The following is a description of a gene set: species: Homo sapiens Human Gene Set: HP_RECURRENT_MALADAPTIVE_BEHAVIOR Recurrent maladaptive behavior A repeating behavior that is either immediately unproductive or has negative long-term consequences. This includes harmful coping mechanisms such as addictive behavior and failure to control impulses and compulsions., and this is the list of marker genes: TAS2R16, KIF14, SETD2, SQSTM1, CLCN2, SLC1A4, SKI, UQCC2, IGF2, FOXG1, PAX4, SLC25A1, SPATA7, BRCA1, DHPS, MEFV, GLYCTK, PDGFRB, DHTKD1, NDST1, DRD2, LEMD3, SLC6A1 (solute carrier family 6 member 1), NR4A2, CDKN1A, NAT8L, EZH2, OCA2 (NCBI Gene Id 4948), CIC, TUBB3, RIC1, UBE2A, SMC5, BANK1, ATR, CTNNB1, ARPC4, BRAF, TMEM240, ZBTB18, IFNG, PSEN2, SYT1, ADH1B, GABBR2, KIAA0319L, TMEM270, ZEB2, SLC25A22, CCND1, SCN3A, HDC, TREM2, FANCL, ZFX, SOX3, CACNB4, KCNH5 (potassium voltage-gated channel subfamily H member 5), SLC9A7, SLC3A1, DALRD3, SMARCA4, CERT1, KMT2A, UBE3A, GABRB2, CSGALNACT1, DDC, ATRX, ASCC3, NOP56, DDX6 (NCBI Gene Id 1656), ZMYND11, PTEN, MPL, PGAP1, OCRL, PNP, GLI3, FZR1, ALMS1, USP8, HIRA, PSMD12, PTPN3, TSC2, LNPK, FGF14, TDO2, TBK1, SMAD4, LINGO1, BAZ1B, KCNQ3, SH2B1 (SH2B adaptor protein 1), FBXW11, BCAP31 (NCBI Gene Id 10134), CEP152, ALKBH8, GRIN2D, GNAQ, PDSS1, CAPRIN1, ATG7, CDH2, GABRA1, RAB39B, GJA5, ATXN10, TRIO (trio Rho guanine nucleotide exchange factor), GNB2, ADCY5, SCAF4, EXTL3, HUWE1, PDGFB (platelet derived growth factor subunit B), MSH6, STAT5B, BCL11A, SIN3A, NAA15, SLC45A1, SLC1A2, CNKSR2, GUCY2D, CILK1, TUBA1A, AP4S1, CYP27A1, NACC1, ZMIZ1, UBE4A (ubiquitination factor E4A), HECW2 (HECT, C2 and WW domain containing E3 ubiquitin protein ligase 2), TAOK1, SMC3, UCHL1, GATA4, CPLX1, GNAI1, DRD4, NPC2, HTRA2, MEF2C, AARS1, IRF2BP2, ATP6V1A, KDM5B, CORO1A, CHD2, GRB10, TACO1 (NCBI Gene Id 51204), RLIM, IQSEC2, PRRT2, ABCD1, ITGAM, GLS, ADCY3, FAS, ASXL3, SLC13A5, VARS1, SNAP25, CBS, NDE1, DPYS, KCNC2, CCNK, TAF4, CLIP2, NPHP1, TTI2, RPS20, ZNF526 (zinc finger protein 526), AVP, TNIK, PCYT1A, AUH, ASPM, DPAGT1, AGO2, HDAC8, ARID1B, SETD5, HTR2A, SPG7, KDM4B (NCBI Gene Id 23030), AP1S2, PAK3, ALDH4A1, PCNT, FLCN, SYNJ1, RAI1, CASP2, CSNK2A1, ACY1, DCTN1, KIF15, NEXMIF, DLG3, SCN8A, EFHC1, HCN1, NSUN6, SLC6A4, AASS, PIEZO2, SLC6A19 (NCBI Gene Id 8062), HTRA1, GPR101, CASR, LZTFL1, NAGS, ZNF365, CHEK2, KMT2E, HEPACAM, TRANK1, DYRK1A, PIGH, KMT2C, HLCS, NIPA2 (NIPA magnesium transporter 2), SOX11, DNAJC12, DNAJC6, ADA2 (adenosine deaminase 2), SLC7A7, IMPDH1, TRAK1, APP (amyloid beta precursor protein), FRMPD4, NARS1, PITRM1, GATAD2B, OFD1, RFX7 (NCBI Gene Id 64864), SHMT2, SLF2, NAA80, TBX2, HLA-DRB1, METTL5 (NCBI Gene Id 29081), KCNN2, ARX, CEP104, FGFR3, MYT1L, KPNA3, TULP1, CHCHD10, NLRP3, IFT140, ASXL1, COG3, SLC52A2, PPP3CA, CDK13, MED13, ABCA2, PRKD1, MICU1, AQP4, ZMYM3, CRB1, HSPG2, CABP4, ANAPC1, GDAP2, BSND, AFF2, UNC93B1, SOX5, KCNA2, FGFRL1, FGFR1, SNRPN, RARA, AP3B2, NPM1, PRKAR1A, ZIC2, GNB1, LEP, GABRA2, CC2D1A, HIVEP2, ITPR3, PDPN, TARDBP, CEP290, FGF13, STT3A, HSD11B2, PYCR2, SIN3B, EMC10, NAPB, GRIA3, UFD1, PTPA, LETM1, DNAJC13, NFASC, FCGR3B, SPEN (NCBI Gene Id 348488), KCNJ5, PHF21A, SYN1, TNFSF4, NSD1, MBD5, DPYD (NCBI Gene Id 1806), CHD3, LARP7, ESS2, LINS1, SLC9A6, PGM2L1 (NCBI Gene Id 283209), MAOA, NLGN4X, PIGY, PODXL, CRELD1, RD3, PDZD8, NSDHL, WDR45, MAPT, SNORD116-1 (NCBI Gene Id 100033413), SLC4A1, PPP2CA, BLK, FANCD2 (FA complementation group D2), PKHD1, SLC5A7, SPTAN1, SZT2, UCP2, AP2M1, RPL10, GTF2IRD1, POGZ, STEEP1, CACNA1D, HECTD4, IGF1, SNCA, DLL1, RHOBTB2, TANC2, POLE, PPP2R1A, PWAR1, IQCB1, CCR1, MC2R, CLTC, BCORL1, FGF12, CTLA4, PTRHD1, STAT3, CR2, EHMT1, TNRC6B, MAPK10, PMS2, POMC, BCOR, PARS2, LIMK1, ASH1L, ELN, RNU7-1, AIP, NFIB, COMT, YME1L1 (NCBI Gene Id 115724), SLC32A1, GNAO1, PMS1, RNU4-2, FLI1, AP1G1, HCRT, HDAC4, NFIA, HSD17B10, FBXL3, MYD88, CACNA1B, SLC4A10, PPP1R12A, ATP13A2, LUZP1, GDF6, MRAP, JARID2, GALT, PIK3CA, KDM3B, CAMTA1, RREB1, H3-3A, CACNA1C, VPS35, ALAD, MAPK8IP3, TUBB4B, ATP10A, PRDM16, ALDH5A1, SOX4, STAG2, CDKN2C, GRIK2, CACNA2D1, TCEAL1, PANK2, GRN, TGFBR2, TLR3, OPHN1, PSMB1, PALLD, DPH2, ZMYM2, STX1B, ECM1, GP1BB, ETS1, ACTL6B, CHMP2B (charged multivesicular body protein 2B), NKX2-1, GALC, PIGQ, GTF2IRD2, CASK, ATM, HGSNAT, CYFIP2, ALG13, KCNJ10, ALPL, WBP11, CDKN1B, CARS1, WDR4 (NCBI Gene Id 55896), LEPR, TRAF3, IL6, ARVCF (NCBI Gene Id 421), GLI2, NDN, COQ5, CD3E, TMEM106B, ABCA12, TSC1, TRIM8, HLA-B, NOVA2, NIPBL, SYT2, NFIX, CSF1R, PGAP3, SGCE, GNS, DGCR8, FOXH1, MC4R, EIF4G1, RUSC2, AIPL1, THOC2, JRK, ABCC8, GNB5, CD247, HNF1B, FOXP1, MED25, CRX, RAD21 (RAD21 cohesin complex component), SH3KBP1, STIL, PTCH1, HAL, PDE2A, PNKP, RPS6KA3, NAGLU, DDB1, GCH1, RAC1, KCNAB2, CHAT, NAA10, INSR, BRD4, SMG8, ADH1C (NCBI Gene Id 126), RABL3, TPH2, C4A, EIF4H, NUMA1, PTCHD1, NEUROG1, GAS1, WASHC4, THRB, ENTPD1, MAP1B, HPSE2, FBXO28, GLDC, EPCAM, KIF5C, KIF11, TMEM231, YWHAG, TLR7, KAT6A, IL1RAPL1, C4B, FMR1, AVPR2, IRF5, NUS1, PRNP, ATP1A3, IRF4, MAB21L1, TNFAIP3, MECP2, UNC80, PWRN1 (NCBI Gene Id 791114), FIP1L1, HOXA2, DCHS1, SPR, DGCR6, SLC25A36, MN1, TICAM1 (NCBI Gene Id 148022), BCR, CACNA1A, EIF2AK1, SLC18A3, WFS1, GABRD (gamma-aminobutyric acid type A receptor subunit delta), GTF2I, PRR12, KARS1, MEIS2, POU4F1, CHD7, DYM, CRIPTO, HNRNPK, SPOP, STAT4, TCF4, PML (PML nuclear body scaffold), WDR26, TSHR, TBL1X, WARS2, NECAP1, MGAT2, ANKRD17, CAMK2B, IFNGR1, CHKA, BBS2, RERE, SYNGAP1, CHRNB2, ZDHHC9, DOCK7, CLCN3, CHAMP1, HNRNPH2, TIAM1, GM2A, GNAS, IKBKG, IFT74 (NCBI Gene Id 80173), CASZ1, SEC24C, ITPR1, CLCNKB, NAA60, NLGN3, TBL1XR1, RDH12, WASF1, TP53, AGO1, NMNAT1, MACF1, CDK19, CTSH, KANSL1, SLC2A3, PRODH, SUCLG1, MKRN3, KLRC4, NFS1, IGHG1, CLDN16, NPAP1, KCTD17, DEPDC5, SASS6, MOG, FGD1, MAN1B1, PDE4D, SATB2, DPH1, MMP23B (matrix metallopeptidase 23B), UBE3C, PLA2G6, DDX3X, IL23R (NCBI Gene Id 94006), IL12B, TKT, HTT, AGPAT2, GNE (glucosamine (UDP-N-acetyl)-2-epimerase/N-acetylmannosamine kinase), IMPDH2, PHIP, PROKR2, CUL4B, SOX2, CISD2, DDX59, SIM1, TLK2, CD3D, FRRS1L, CHD8, CDC42BPB, FTSJ1 (FtsJ RNA 2'-O-methyltransferase 1), PRKAR1B, SRSF2, CDK10, SCN1B, KCNJ11, EBP, SLC41A1, CDKL5, TRAPPC6B, FMO3, UBTF, ODC1, WDR62, RTTN, TNPO2, TRAPPC14, CDKN2A, BAP1, COL13A1, PREPL, IL12A-AS1, PDCD1, SHROOM4, KCNA4, ATP1A1, RUNX1, MSH2, CDKN1C (cyclin dependent kinase inhibitor 1C), OTX2, KMT2B, GCSH, MUTYH, WAC (WW domain containing adaptor with coiled-coil), UBE2L3, TBP, CDKN2B, GRM7, ACBD6, NTRK2, ZBTB20, NDP, CAMK2G, SRCAP, PACS1, CELF2, DRD5, KAT8, WBP4, SARS1, TET3, NR2F1, SRPX2, GLA (galactosidase alpha), DPYSL5, P2RY11, KMT5B, FBXO11 (F-box protein 11), TBX1, SETBP1 (SET binding protein 1), NPHP3, NAXD, OTC, CDC73, ERAP1, UBE4B, PSEN1, GJB2, TTI1, SMARCD1, APC2, PRKN, JAZF1, SLC2A1, PXK (NCBI Gene Id 54899), LCA5, CHD5, PIGL, MCTP2, HEPHL1, STXBP1, ATP7B, UPF3B, DHX30, SHOC2, ADAT3, ARG1, BSCL2, EXT2, SLC12A3, JMJD1C, SHANK3, BBS9, PPP1R21, AP4M1, MED12 (NCBI Gene Id 9968), PIGS, SLC35C1 (solute carrier family 35 member C1), NABP1, NLGN1, DNMT1, DNM1L, SLC7A6OS, PINK1, TRAPPC10, DMPK, EBF3, NAA20, TYROBP, LMNB1, GLUD1, TET2, TRIP12, NALCN, ADGRV1, SLC6A8, KCNJ13, RPE65, CHRNA2, MLH1, KCNT1, JAK2, SATB1, SIK1, NKAP, PCGF2, P4HA2, MED13L (NCBI Gene Id 23389), VCP, LRRK2, BPTF, KNL1, SLC38A3, KCNA1, TBL2, RAP1GDS1, TCF20, AP4B1, CRH, PPM1D, VANGL1, VAMP1, UBAC2, IVD, SLC46A1, CREBBP, FLG, AGRN, PRKCZ, FOXP2, IMPA1, FCGR2B (Fc gamma receptor IIb), DGCR2, ARID1A, IQSEC1, NBEA, AFG2A, ZSWIM6, DENND5A, BICRA, FAT4, DEAF1, SUGCT, DYNC1I2, AFF3, HPRT1, GRIA2, SCN2A, AP4E1 (NCBI Gene Id 23431), NIPA1, TAF1, MMUT, RELN, IL10, PCDH19, PLCH1, TREX1, SORL1, SVBP, LHCGR, TRRAP, USP45, TBC1D23, ABCA7, PUF60, DNASE1, NSD2, ATP6V0A1, H4C5, ADGRL1, DNAJC19 (NCBI Gene Id 131118), NPHP4, VPS16, SLITRK1, FKBP6, CBL, GRIA1, EIF2S3, TNIP1, MMADHC, YY1, SCN1A, LGI1, SMARCE1, SUPT16H, TSHB, SLC19A2, SHQ1, ZNF699, APOE, RBL2, NONO, GRIN2A, USP7, CHRNA4, AHDC1, PLAG1, PARK7, COASY, PUS7, EEF1A2, NTNG1, NRCAM, NF1, CYP11B1, TMCO1, CDH11, SCARB2, NBN, FUS, BRF1, ASL, GBA1, TOMM40, SCN9A, SYK, TOR1A, FGF8 (NCBI Gene Id 2253), CLTCL1, CDON, GABRG2, SPTBN1, ALG14, PCSK1 (NCBI Gene Id 5122), TTC5, FIG4, PIGP, SPP1, HLA-DQB1, GJA8, KCNK9 (potassium two pore domain channel subfamily K member 9), TBR1, VPS13A, PRKCG, MEN1, TBCD, RBBP8 (RB binding protein 8, endonuclease), CCBE1, TGFB1, MRPL39, STX1A, SLITRK2, AQP2, MADD, PUM1, INPP5E, SEMA4A (NCBI Gene Id 64218), ANKRD11, NODAL, BCKDK, ATP9A, METTL27, FTL, SGSH, MANBA, ARID2, CLDN10, KCNJ1, POLA1, HMGA2, VPS37D, HMGCL, FERRY3, VPS13C, STS, RORB, GABRA5, SMARCC2, RPGRIP1, USP9X, CDK8, PIGF, HNRNPR, VAMP2, DNMT3A, HERC2, TELO2, SIX3, ZNF292, ATP1A2, ADH5, KAT5, TMEM67, SNORD115-1, CHD1, PUS3, CTBP1, DISP1, MYO9A, RFC2, ACAT1, BUD23, LIG4 (NCBI Gene Id 3981), MAPK1, ANK3, KL, UROC1, MLXIPL, SCAPER, TUBB2B, LRAT, TMEM147, EIF4A2, TPR, NTNG2, CTNS, SEMA3E, MAGEL2, XK, KRAS, AUTS2, DPF2, PDCD6IP, NSUN2, MTOR, RSRC1, C12orf57, ZBTB16, SMARCB1, CUX2, TAF6, HNRNPC, GABRB3, TLR4 (NCBI Gene Id 7099), PPP2R5D, DHCR7, POLD1, SPAST, STAR, PTPN22, CYP11B2, UBA5, NEUROD2, TXNRD2, EP300, DCDC2, DNAJC30, KDM6B, LGI3, ARNT2, GABBR1, SHH, NTRK1, WWOX, PACS2, SMARCA2, TRAPPC9, DHDDS, DNM1, CUL3, SLC1A3, BMPR1A, NEK8, KPTN, SPRED1, TTC19, GAMT, CACNA1H, KCNB1, SETD1A, CNTNAP2, IL12A, SLC25A13, ADNP, PALB2 (partner and localizer of BRCA2), DNAJC21, FUZ, MED12L (NCBI Gene Id 57726), NNT, ELP2, TIMM8A, TFE3, IRAK1, LMAN2L, CHRNA7, NCF1, ADSL, RAB11B, SMPD1, PAH (NCBI Gene Id 5053), SCN4A, GRIN1, CEP85L, UBAP2L, LRIG2 (NCBI Gene Id 9860), SMC1A, SRRM2, GIGYF2, DZIP1L, SLC6A17, TUBG1, ROS1, SLC5A2 (solute carrier family 5 member 2), TGIF1, KYNU, C19orf12, CTCF, CRBN, CLCN4, SOX6, FLII, TMEM222, MLX, DMXL2, TBC1D2B, KDM5C, BRCA2, HESX1, DPP6, PIDD1, GLRA2, HNF1A, CRKL, CALR, ATP5F1B, MID2, TIMM50, SLC39A4